Given this list of marker genes EPOR, TLE4, KCNJ16, CRYAB, CLASP2, SYNDIG1, MORF4L2, NR3C1, HIPK1, TEK (NCBI Gene Id 7437), RHOT1, TARDBP, LUC7L3, ITGA6, CAB39, MTPN, NCOA7, PPP1R12A, PRKCB, ZNF608, AKAP9, TMF1, TUBA1A, CYP1B1, RAB8B, CDK6, AP3B1 (NCBI Gene Id 8546), SPOCK1, PCDH19, ASCL1, VAMP7, NCAM1, MMAB, CAMTA1, FLRT2, SYCP1, FAM124B, OSBPL10, GRIA3, GFM1, RPL15 (NCBI Gene Id 6138), PCYT1A, GABRG2, GOLGA6D, SMYD2, MAGI1, KCNRG, TMEM245, HDGFL3, CYP4F11, TBKBP1, KCNK9, SCN9A, CCNYL1, TYRP1, PTPRM, ZDHHC21, TMEM178B (transmembrane protein 178B), TANC1, GOLGA6B, BRWD1 (NCBI Gene Id 54146), PIK3CB, MAP6, MOAP1, RBBP7, GOLGA6C, GOLGA6A, ANKRD44, ATP10D, CDC42SE2, SYT15, MSI2, RUNX1T1, ZNF518B, ZNF22, GLI2, SLC1A2 (NCBI Gene Id 6506), TAFA2, PAXBP1, ITGA1, GPBP1L1, CPE, SLC12A5, SMURF2, ATXN2, RPAP1, PPP2R2A, NEK7, ANO3, GPRIN3, SGCD, SKAP2, SLC15A1, RABGEF1, ID4, FAM218A, VSIG1, NUB1, PPP4R2, CTXN2, ZNF432, FBXL7, RRAGB, MPC1, ZEB2, RNF19B, ALDOA, GPM6A, OPA1, TMEM267, CACUL1, CANX, CHML, RHPN2, CD93, CHGB, GRIA2, METAP2, PICALM (phosphatidylinositol binding clathrin assembly protein), SCAI, BRWD3, KPNA4, SCN1A, ADCYAP1, here is a description of the gene set: species: Homo sapiens from publication Chen Y, Wang X (PMID 31504780) Human Gene Set: MIR1179 Genes predicted to be targets of miRBase v22 microRNA hsa-miR-1179 in miRDB v6.0 with MirTarget v4 prediction scores > 80 (high confidence targets).